The following is a description of a gene set: Exodeviation studied in species Homo sapiens A manifest or latent ocular deviation in which one or both eyes tends to deviate temporally. Human Gene Set: HP_EXODEVIATION, and this is the list of marker genes: WDR45, THOC2, SOX5, SLC32A1, UBAP2L, MYF5, DPAGT1, PTRH2, SLC1A3, ADD3, POLRMT, FGF10, CRIPT, TGFBR1, TRAPPC11, TYR, PHOX2A, U2AF2, ITPR1 (NCBI Gene Id 619543), CRELD1, LYRM7, DNMBP, CDH11, FGFR3, TAF2, CACNA1F, UBE3A, NEDD4L, GMPPA, RERE, FBN1, KIF21A, EIF4A2, ALDH3A2, WARS2, OCA2, GJA5, MADD, HNRNPH2, SMAD3, ZC4H2, MRPS34, HMX1, MRPS2, POGZ, PAX6, TMEM67, SLC35A2, BCOR, SPATA7, GRIA1, PCDHGC4, ADGRG1, UFSP2, GNB1, DYRK1A, IFT27, FGFR2, PRR12, NONO, CDC42, CRB1, ANKH, GJA8, EXOC8 (exocyst complex component 8), SALL2, TUBB3, RNH1, MTRFR, ADARB1, ADNP, NMNAT1, KDM6B, ATRX, CDKL5, EFNB1, PYCR2, AIMP1, SLC25A46, WT1 (WT1 transcription factor), LCA5, RPL10, MC1R, TUBA1A, GNB2, LRAT, LRMDA, HADHA, SON, NR2F1, HACE1, AFG2A, COL4A1 (collagen type IV alpha 1 chain), TBX1, CACNA1A, SLC6A8, RPE65, NGLY1, COL25A1, FBXW11, RP1L1, BLOC1S3, SIAH1, WDR11, RPGRIP1, SNRPN, CBS, TRPM3, PUF60, ACADSB, TGFBR2, ATP1A3, RNF2, SCO2 (synthesis of cytochrome C oxidase 2), PGM2L1, SLC17A5, BCORL1, PRPS1, ATP1A2, HPDL, KDM1A (NCBI Gene Id 23028), AFF4, GALNT2, H4C5 (NCBI Gene Id 8367), TUBB2B, ARPC4, AHDC1, PYROXD1, P4HTM, ATP13A2